The following is a description of a gene set: Left anterior fascicular block Conduction block in the anterior division of the left bundle branch of the bundle of His. Human Gene Set: HP_LEFT_ANTERIOR_FASCICULAR_BLOCK studied in species Homo sapiens, and this is the list of marker genes: TRPM4, TNNC1, FLNC, ACTC1, LMNA, TNNI3K, SCN5A (sodium voltage-gated channel alpha subunit 5)